The following is a description of a gene set: CREB3 factors activate genes species: Homo sapiens Human Gene Set: REACTOME_CREB3_FACTORS_ACTIVATE_GENES, and this is the list of marker genes: CREB3, CREB3L3, CREB3L2, CREBRF, CREB3L1, MBTPS1, MBTPS2, DCSTAMP, CREB3L4